Given this list of marker genes Hmox1, Rabgef1, Spi1, Cx3cr1, Abr, Bcr, Ccr2, Foxf1, Cd300a, Il13ra2, Cd84, here is a description of the gene set: Mouse Gene Set: GOBP_NEGATIVE_REGULATION_OF_MYELOID_LEUKOCYTE_MEDIATED_IMMUNITY Any process that stops, prevents, or reduces the frequency, rate, or extent of myeloid leukocyte mediated immunity. studied in species Mus musculus